Given this list of marker genes ASB8, CBX7, ITGAV, COL19A1, TMEM132B, SPATA2, EPS8, CBX3, HIC2, CPEB3, TERB2, CAB39, COG3, MCM10, NUDT11, ARHGAP5, ESPL1, MYO5B, SLC7A11, NEUROG2, BEND4, TRAPPC9, SLC44A1, BNIP2, SGPP2, IQGAP2, ZBTB20, SUCO, MAN1A1, CADM2, IGF2BP3, CEBPZOS, PKNOX1, FGF9, RBBP7, NARS2, RINL, TRIM9, SLC17A4, AKR1C3, SLC4A7, MYO1H, GFPT1 (glutamine--fructose-6-phosphate transaminase 1), PCDH11X, QKI, MMP21, STON1-GTF2A1L, BTF3L4, SCML2, LIN7C, TENT2, ADAMTS19, GTF2H5, MYO1D, CCNY, SMC2, VGLL3, LSM11, PIAS2, FSIP1, BSN, KCNJ3, MBNL2, ETV1, CUL3, YIPF5, NCKAP1, PROK2, HNRNPU, SLC4A10, CCDC88C, MTX3, CLPX, DHRS2, TBC1D15, SYTL2, RNF5, INO80D, ADNP2, LIMS1, ZEB1, RICTOR, MBD2, ZNF805, ATP5MGL, UBXN2B, RECK, TLR1, PXN, YIPF6, CSPP1, ZNF236 (zinc finger protein 236), SORL1, ZMYM4, ARL13B, CDC5L, SCAI, SLC31A1, MARK1, GALR1, C5orf22, GREB1, MDM2, OCIAD1, NEGR1, RFX3, GABRG3, CEP350, RALBP1, SNX27, XRN1, CPE, PTPN4, LRRC40, FSBP, ELAVL1, HEATR5B, STRBP, TAT, RMI1, DDX4, SLC10A7, SEC23A (SEC23 homolog A, COPII coat complex component), CLDN22, SSX2IP, RAP2C, RAB2A, EPB41L4B, CHORDC1, SF3B1, SHANK2 (SH3 and multiple ankyrin repeat domains 2), RAD51B, CYP3A5, TASOR, VPS13C, RNF11, NHS, SSH2, PARPBP, SYT16, PHLPP1, ANKH, CPD, CEP97, PPP4R2, PPP1R2, MAP3K2, TET2 (tet methylcytosine dioxygenase 2), PANK1, NRN1, THAP12, FSD1L, RDX, LNX2, GLS, ZCCHC14, YTHDF1, SLC7A14, PFKFB2, ALDH1A1, PURA, CCDC93, LIMCH1, SMC5, TP53TG3, ERBIN, CDK14, TSHZ1, CCNC, AFF4, GABPB1, KCNA1, MAGEB4, TRMT10A, EP300, TC2N, ONECUT2, RETREG1, MIA2, PCDH7, KCND2, FUBP3, DICER1, BRWD3, SECISBP2L, CPSF6, KLHL5, PLIN1 (perilipin 1), DMP1, HIPK3, MGAT4B, NUP160, TBC1D23, SCD, KPNA3, ZBTB14, MYEF2, UBE2D3, SLC39A9, PAH, NRG3, SLC35A3, MICU3, DCAF17, COL1A2, HECW1, C6orf58, NLN, UBA5, PCDH17, GGACT, ZNF610, NALCN, ELL2, SEL1L, AGTR1, RSBN1L, MAP4K3, TP53TG3B, NDUFA5, ENAH, SLA2 (Src like adaptor 2), CAPZA1, CENPK, NR2E1, CCT2, TOMM70, PCID2 (NCBI Gene Id 55795), SP8, SEPTIN2, SAT1, CHD9, PRR16, RAB18 (RAB18, member RAS oncogene family), PALS2, PXYLP1, WAPL, MSL2, KCNQ3, JAG1, FNDC3B, TM4SF4, NUP42, ADH7, CENATAC, DPY30, ST13, IREB2, TRPV3 (NCBI Gene Id 201131), MTMR6, CCN4, NADK2, RSF1, MGAT1, ZXDA, IL26, FGF12, PELO (NCBI Gene Id 53918), GUCY1A2, UHRF2, USP37, EDIL3, EIF3A, KLRC3, RPS6KB1, SMARCA5, ZNF638, ERCC4, FAM120A, AP3M1, MYCN, PHC3, NUFIP2, KLHL15, TMEM245, ZC3H12C, DCAF12, MAB21L1, SLC30A4, ZBTB11, KLHL28, ARL4A, SDK2, PABPC1, GIPC2, SRSF6, ATAD2B, NUDT16, BIRC6, ARF6, MAP3K13, GOPC, MYLK, TRIM8, MOCS2, ELAPOR2, RAP2A, STX16, PLCL1, ZNF354C, IRF2BP2, ATP5MG, MTDH, ESR1, ZC3H18, TMEM33, GOSR1, DNAJB14, LRP6, YBX1 (NCBI Gene Id 7806), CDYL2, ZBTB34 (zinc finger and BTB domain containing 34), PRPF40A, NETO1, SPTY2D1, FAM91A1, SRRM1, DCX, PABPC3, GALNT7 (polypeptide N-acetylgalactosaminyltransferase 7), SP100, KIAA1210 (NCBI Gene Id 57481), FOXA1, PARD6B, TMEM170A, CPEB4, FLT1, UBE2G1, HSD17B7, NEMP1, PAX5, SERINC3, ZFX, MEX3C, ZNF770, ANK2, ANGPT1, FAT1, TMLHE, CNTN1, SLC6A15, FUT9, GRPEL2, MLLT10, CIP2A, NR3C1 (NCBI Gene Id 389335), TCF12, TMX4, LRRC8B, EXOC4, FAXC, MARK2, ANO3, PCDH9, GABRG1, DTWD2, GNG10, CILK1, NHLRC3, FIRRM, DMD, TMEM47, RERE, GABRB3, HSD17B6, SH3TC2, FZD3, NARS1, DPH6, UCHL5, SLAIN2, SAMD4A, ACER3, ZBTB21, TMEM35A, FBXL17, TMEM170B, S1PR1, MIER3, CDH20, NOVA1, NAA50, PPP4R3A, LPP (NCBI Gene Id 4026), PEX3, ACTR3, NCOA7, USF3 (upstream transcription factor family member 3), DPP8, TNFAIP8, ECT2, TRAK1, ASTN2 (NCBI Gene Id 23245), AAK1, SERP1, UBE2E2, ZHX2, SOX11, SCAMP1, STAC, NOX4, A1CF, EPB41L3, RND3, BAHD1 (NCBI Gene Id 22893), ATM, PHIP, EPHA3, MAP3K7CL (MAP3K7 C-terminal like), STK3, DPY19L3, FOXO3, ALG13, SHOX, CDC14A, HRH1, CNKSR3, HEY1, ARMC8, PPP1R9A, ARPP19, BARD1, TIMM10B, WDR26, IGF1, EIF5A2, CLINT1 (NCBI Gene Id 9685), SESN1, AFAP1, CASZ1, ZFHX4, BPNT2, NR1D2, UBR7, TMPO, BTBD7, ENPEP, TWSG1, SNX10, LARP4B, NBEAL1, USP25, SMAD2, RALGPS2, ERO1B, MPPED1, NAALADL2, GASK1B, C12orf56, ALCAM, PPP1R15B, PLAC8, RAD54B, TTC28 (tetratricopeptide repeat domain 28), PCNX3, PHF20L1, GPM6A, MKRN2, DGKH, ZBTB41, FEM1C, CUL5, PPHLN1, DPYD, MMAB, FGFR2, STIMATE, HOOK1, CLDN11, FHIP1A, BTAF1, PRKAA1, YOD1, SGPP1, SLC9A4, PER3, RAB11A, LTA4H, CECR2, BMPR2, SLC35F1, MTX2, RASSF8, COX7A2L, TRAPPC10, TP53TG3D, PPP1CC, ATXN10, CLOCK, MEIS2, SLC27A1, PCDH11Y, MBNL1, RBM12, IL1RAP, TSPYL1, PROX1, GALNT1, CREBBP, FCHO2, NRXN1, PPM1L, ANKRD10, ITGA2, FBXO8, SERPINE1, ZDHHC21, here is a description of the gene set: studied in species Homo sapiens Genes predicted to be targets of miRBase v22 microRNA hsa-miR-551b-5p in miRDB v6.0 with MirTarget v4 prediction scores > 80 (high confidence targets). Human Gene Set: MIR551B_5P from publication Chen Y, Wang X (PMID 31504780)